The following is a description of a gene set: species: Mus musculus Mouse Gene Set: GOBP_PURINE_DEOXYRIBONUCLEOSIDE_MONOPHOSPHATE_METABOLIC_PROCESS The chemical reactions and pathways involving purine deoxyribonucleoside monophosphate, a compound consisting of a purine base linked to a deoxyribose sugar esterified with phosphate on the sugar., and this is the list of marker genes: Adk, Uox, Urah, Guk1, Nt5c2, Urad, Ada, Dck, Xdh, Gda, Nt5c, Dnph1, Dguok, Pnp, Nt5c1a